Given this list of marker genes POC1A, TRIP11, TSKU, TGFBR2, MATN1, IHH, COL27A1, NPPC, AXIN2, SERPINH1, SMPD3, RARG, SOX9, ATF2, IFT80, here is a description of the gene set: The process in which a chondroblast acquires specialized structural and/or functional features of a chondrocyte that will contribute to the development of a bone. A chondrocyte is a polymorphic cell that forms cartilage. Human Gene Set: GOBP_CHONDROCYTE_DIFFERENTIATION_INVOLVED_IN_ENDOCHONDRAL_BONE_MORPHOGENESIS studied in species Homo sapiens